Given this list of marker genes STAG2, ERG, DNPEP, ARNT, DNAJB13, SHISA6, HIPK1, CLDN8, ZNF784, PYM1, DDB1, MIDEAS, MTCL2, MECP2 (methyl-CpG binding protein 2), SHROOM4, CASP14, XKR5, C10orf55, FBXO28, MCCC2, ADAM12, MAVS, LRRC27, IGFBP3, TLCD3A, CLVS1, GLG1, KRTAP4-12, KPNA3, ATP1B2, ATXN1, ARMC6, PAX8, TBC1D16 (TBC1 domain family member 16), MIS18A, CHRDL1, TRIM66, EFCAB14, FAM78A, ZNF230, ZNF714, HEY2, PDE6D, KIF21B, COX6B1, DCLK1, ANKRD24, TIPRL, L3MBTL3, BCAM, PLEKHH2, SPON1, FRMD5, NLRP13, NHLH1, FAM169BP, LDHAL6B, TSPEAR, RBM20, TMEM101, MKI67, RAPGEF2, SP2, GPATCH1, ANKRD50, IQSEC2, TEX2, here is a description of the gene set: from publication Chen Y, Wang X (PMID 31504780) Genes predicted to be targets of miRBase v22 microRNA hsa-miR-7154-3p in miRDB v6.0 with MirTarget v4 prediction scores > 80 (high confidence targets). Human Gene Set: MIR7154_3P studied in species Homo sapiens